Given this list of marker genes TNNC1, SELENON, ATP8A2, DDIT3, GAA, here is a description of the gene set: Human Gene Set: GOBP_INVOLUNTARY_SKELETAL_MUSCLE_CONTRACTION studied in species Homo sapiens A process in which force is generated within involuntary skeletal muscle tissue, resulting in a change in muscle geometry. Force generation involves a chemo-mechanical energy conversion step that is carried out by the actin/myosin complex activity, which generates force through ATP hydrolysis. Involuntary skeletal muscle is skeletal muscle that is not under conscious control.